Given this list of marker genes Trim55, Itga4, Crkl, Fer, Pecam1, Cd99l2, Crk, Ccl5, here is a description of the gene set: Mouse Gene Set: GOBP_DIAPEDESIS The passage of a leukocyte between the tight junctions of endothelial cells lining blood vessels, typically the fourth and final step of cellular extravasation. studied in species Mus musculus